Given this list of marker genes MIR195, ADPRHL1, NOTCH1, S1PR1, MESP1, here is a description of the gene set: studied in species Homo sapiens Developmental growth that contributes to the shaping of the heart. Human Gene Set: GOBP_GROWTH_INVOLVED_IN_HEART_MORPHOGENESIS